The following is a description of a gene set: Any process that stops, prevents, or reduces the frequency, rate or extent of a process involved in the formation, arrangement of constituent parts, or disassembly of cell structures, including the plasma membrane and any external encapsulating structures such as the cell wall and cell envelope. species: Homo sapiens Human Gene Set: GOBP_NEGATIVE_REGULATION_OF_CELLULAR_COMPONENT_ORGANIZATION, and this is the list of marker genes: APOC3 (apolipoprotein C3), NUF2, INCENP, ACE (angiotensin I converting enzyme), CDCA8, ESPL1, DPYSL3, SEMA3G, MIR18A, DNAJB8, MIR205, TRPV4, HES1, TERF1, DLG4, SSH2, ROCK1, LRSAM1, FAT3, IFI16, SLC35F6, XRCC1, TPX2, PHLDB2, IAPP, RLF, NME6, MEFV, GFI1, BIRC5, TBX6, TNFRSF1B, NTN1, SPTB, TRIOBP, CLASP2, CD300LF, KATNB1, PSEN1, FBXO43, CCNF, SPEF1, ARHGEF18, DYSF, FXN, ZNF365, PTPN13, RHPN1, NBN, TBC1D4, TBC1D30 (TBC1 domain family member 30), ACP4, TRIP13, KIF24, FEZ2, PRRT2, DNM2, NBDY, RECK, OPA1, MAD1L1, MUL1, TLR2, NUPR1, CERS2, SPTBN2, ATXN2, NLRC3, EPHB2, TREM2, TLX2, MET, ARHGEF7, RAB29, KAT2B, LIMK2, TERF2IP, ULK1, PCSK9, STMN3, CAPZB, H3-3A, YWHAH, TINF2, ZNF296, JPX, DAB2, FLII, EFNA1, C11orf65, PGRMC1, PRKN, CAPZA3, SSH1, DGUOK, HRG, PFN1, CCNB1, PACSIN1, MCF2, MIR98, CAPG, RIT2, EFNB2, SPTBN4, RNF6, NLGN1, CEP97, CLSTN3, CARMIL1, TRIM31, VAT1 (vesicle amine transport 1), MIR138-1, LAMP2, TRIM32, IFRD1, THOC2, MIR29C, TFIP11, DNAJB2, APOA4, WNT3, ATRX, MIR219A1, MIR145, ARF6, MAD2L1BP, BCL11A, CHADL, FIGNL2, BECN1, KIF14, BBOF1, HDGFL3, SLC25A6, RCC2, ADAM17, HMGB1, TRIM37, TRPC6, APOA1, ISL1, TTK, SH3GL3 (NCBI Gene Id 6457), CAV3, CDC20, LMOD3, MMP14, MIR30B, KIAA0319, TBC1D7 (NCBI Gene Id 51256), SORL1, AURKAIP1, CDK5, FAM107A, DACT1, SSH3, WASF2, STAP1, HSF1, THBS1, MIR19B1, ARHGAP28, MYLIP, SOST, STXBP1, CYRIB, PARP3, TRIAP1, IRAK3, PON1, KNL1, ARHGAP4, GAK, RAP1GAP, MTOR, PTPRG, VPS35, ZNF827, SETMAR, DCP2, NFATC4, SLC25A5 (NCBI Gene Id 292), MIR24-1, PTPN1, JAM3, SRGAP2C, PRAP1, EPHA4 (NCBI Gene Id 401031), IQCJ-SCHIP1, RAPGEF3, ANKRD27 (NCBI Gene Id 84079), PTPRS, MIR20A, WASHC2C, EPHA3, RIOK3, MYOC, FBXO5 (F-box protein 5), DUSP1, PRKD1, NEO1, PPARG, MIR142 (microRNA 142), BMP6, LUZP1, EFNB3, APOD, LILRB1, TMOD1, HIGD1A, RHPN2, MIR149, RDX, TNKS2, BUB1, NEUROD2, MIR19A, TMOD4, B2M, BCL2L1, ZNF207, IER3, PFDN1, MCRS1, CENPF, CAPZA1, AMIGO3, CD300A, MIR185, PAQR3, YAP1, SMCR8, CDC42, SPP1, ANKRD13A, IFI6, LMOD1, PFDN5, SLIT2, RGMA, GNL3L, SEMA5A (semaphorin 5A), KAT2A, SMARCA5, NAT10, FCGR2B, BIRC2, RAC1, FSTL4, PFDN6, HNRNPC, DRAXIN, PRTN3, SPTBN1, SVIP, SIRT2, CIB1, CPTP, RTN4, CCDC88C, SDCBP, ABHD8, RHPN2P1, HSPA1A, MDM2, RAB7A, TOGARAM2, TSKU, EPHA7, FGF13, DUSP22, MIR210, SLC25A4 (NCBI Gene Id 7872), CCP110, TESK1, ARAP1, IKBKB, PYDC5, CTNNA2, CCL21, SPC24, CTC1, SEMA6D, MT3, SEMA4F, DPYSL5, ARHGAP44, NECAB2, DNAI3, L3MBTL3, HASPIN, SPECC1L, TRIM54, LMO4, DAB1, ITGB1BP1, NRXN1, PLSCR1, MINAR1, TNF, CORO1B, PROM2, TPR, ACVRL1, PPP3CA, EP300, CDH5, APC, SLN, SPOCK1, ARHGAP6, PTGER4, ODF2L, SNAPIN, POT1 (protection of telomeres 1), ANKRD13B, TNKS, RABGEF1, TNFRSF1A, SPART, AKT1, SVIL, TEN1, SKA3, F11R (F11 receptor), NOTCH1, CLU, GFAP, TWF2, CARD8, PSMG2, PIP4P2, TWF1, ADD2, IRGM, SNX33, KMT2A, MIR17, ATM, PACSIN3, CSK, CRYAB, SPC25, ADCY6, ATXN7, ARHGEF2, NPM1, EVI5L, MIR196A1, LCMT1 (NCBI Gene Id 51628), PYDC2, WNT5A, EXOSC10, MIR27B, CD38, RPL13A, MIR199A1, CHEK1, MIR9-1, SPTA1, ARHGAP24, HSPA1B, DDX3X (NCBI Gene Id 730543), BOK, MAPRE1, TJP1, BUB3, ADCK1, CRACD, SPRY3, CARM1, TRIM46, PINK1, SLX4, GHITM, GEN1, BAZ1B, MGARP, MAK, TMSB4X, EML2, GPX1 (NCBI Gene Id 2876), FRMD7, CRMP1, NANOS2, TGFB1, ACAA2, GRIN2B, VIL1, SEMA6C, TNR, SNX3, TMEM67, RPS6, PATL2, MAP6D1, ROBO2, MARCHF7, LDLR, ADD3, CNN2, RAF1, BNIP3, SHANK3, CXCL10, APOM, HSPA8, KANK3, LIF, NDC80, SACS (NCBI Gene Id 26278), DLC1, ITGA3, MAG, TGFBR3, CKAP2, FKBP4, PHF8, PPIF, PINX1, OAZ3, MYADM (NCBI Gene Id 91663), ZW10 (zw10 kinetochore protein), SNCA, SLX1B, ASB2, WNT3A, APPL1, INPP5J, CSNK1A1 (NCBI Gene Id 55416), H3-3B, EVL, GDI1, S1PR1 (sphingosine-1-phosphate receptor 1), DNAJA4, TENT4B, KANK2, IL15RA, RAB3IP, NR1H4, LRRK2, PML, APOA2, HGF, ABCA2, SCIN, PAFAH1B1, TMOD2, MAD2L1, MID1, STYXL1 (NCBI Gene Id 51657), MIR105-1, PHF2 (NCBI Gene Id 79448), SIRPA, HSPG2, ZWILCH, DNAJB1, SEC22B, MIR181B1, DPP4, ANKRD13D, JMJD6, SYT11, INPP5F, APC2, PHF23, USP10, MDM1, HIP1R, TOM1L2, CORO2B, PRP4K, EHMT2, MTPN, PFDN2, FNIP1, CD47, PPFIA1, TMEM182, BMP7, RUFY3, TP53, NGEF, FZD9, SEMA3F, GMFG, RUBCN, LMNA (NCBI Gene Id 7816), SLX1A, DYRK1A, SKA1, PIK3R1, PRKCZ, MCTP1, BBS4, ABHD17A, GAS2L1, HSPA2, NLRP2B, ARPIN, NAV3, VILL, XRCC3, MPV17L, CST3, CFLAR, HNRNPA1, PICK1, ZDHHC12, TUBB4A, SWAP70, TBCD, KANK1, CDH1, MTMR2, LILRB2, NR1H3, INPP5K, RTCA, MTBP, CFL1, EMILIN1, PMP22, THY1, NOP53, PLXNB3, RAD21, CLASP1, GDI2, HNRNPU, SAMD1, RTN4RL2, HSPA5, TACSTD2, CDK5RAP2, NRP1 (NCBI Gene Id 8829), PRNP, PTPRO, MPHOSPH9, TRAF3IP1, ARHGEF15, ADTRP, TTBK2, SYNGAP1 (NCBI Gene Id 8831), KLHL22, ITM2C, TRIM65, CORO1A, WAS, ULK2, STMN1, FLCN, PFN2, BRCA1, NAA10, SCFD1, CAMSAP2, ADIPOQ, DIP2B, PRKCD, IFNB1, RAPGEF2, HUWE1 (NCBI Gene Id 54789), TOM1L1, ZWINT, CORO1C, PARK7, DMTN, BMP4, PLK1, STN1, CAPZA2, PLEKHH2, RTN4R, NEU3 (neuraminidase 3), AURKB, RAD50, DIAPH3, NUBP1, LRRTM1, HORMAD1 (NCBI Gene Id 84072), CBLN1, HDAC6, PICALM, GLCE, TCHP, ABCA7 (NCBI Gene Id 82843), IL1B, LPAR1, DNMT3L, STMN2, LGALS3, ABI3, UNC119, IK, RTN4RL1, SCAMP5, OMA1, CGNL1, PRELID1, VBP1, ANAPC15, LIMA1, TERF2, PYDC1, KNTC1, WDR54, GSK3B, PACSIN2, SEMA3A, AVIL, TFRC, TMOD3, PFDN4, GMFB, DNAJB6, MAP1B, RBM14, VIM, SCAF4, PAK2, DCC, ATG5, CTNNBIP1, MIR214, PEX5, PTPN9, MIR31, MAP2, MIR92A1, LRP4, MAP4, IGF1, AIDA, CLEC16A, APOC1, OPRD1 (opioid receptor delta 1), ACD, MIR483, DYNC1LI1, MIR515-1, ROCK2, PLXNA3, TMEM14A, NR2F1, PIF1, KREMEN1, XRCC5, NR1H2, SHANK1, PIK3CA (phosphatidylinositol-4,5-bisphosphate 3-kinase catalytic subunit alpha), AKAIN1, UBQLN2, CLIP3, THRA, KDM1A, XRN1, NOL3, DNAJC15, TIMP3, RYK, SOX9, RAD1, PTEN, CDK10, PSMD10, GBA1, WDR47, MIR29B1, FYN, TRAK2 (NCBI Gene Id 66008), TMC8, RIN3, ERCC1, DKK1, SPRY2, SMAD4, LRIG2, WASL, MIR21, ARFGEF1, BUB1B, BMERB1, CARMIL2, SLC25A31, BAG5, MAPT, EPS8, FBXL2, LRPAP1, SLIT1, ADD1, TMEM39A, ATG3, BAK1, USP44, NEU4 (NCBI Gene Id 129807), TMEFF2, CRBN, RTEL1, ANXA2, FEZ1, LMOD2, VEGFA, GAS2L2, DENND5A, APOE, CENATAC, CDKL3, SCAF8, ANTXR1, PRAG1, RPS6KA2, OGT, MKKS, DMRT1, APOC2, TRIM11, CAV1, CBFA2T2, MIR92B, SPDL1, MTM1 (myotubularin 1), STX1B, ANGPTL4, SPTBN5, RACK1, KANK4, PARP1, GORASP1, HDAC2, GCLC, SPTAN1, GSN, LRRTM2, WAPL, ERCC4, TAOK1, MID1IP1, PARL, CH25H, FAP, ANGPTL3, DTNBP1, TRPC5, SRC, WDR44, UBQLN4, SMG6, MAD2L2, TEX14